The following is a description of a gene set: Any process that modulates the frequency, rate or extent of the chemical reactions and pathways involving polysaccharides. Mouse Gene Set: GOBP_REGULATION_OF_POLYSACCHARIDE_METABOLIC_PROCESS species: Mus musculus, and this is the list of marker genes: Phlda2, Pdgfb, Epm2aip1, Cltc, Smpd3, Prkag3, Akt2, Ppp1r3g, Ppp1cb, Phka1, Enpp1, Ptger4, Mtor, Gck, Tgfb1, Gcgr, Hmgb1, C1qtnf2, Akt1, Ppp1r3b, Grb10, Inpp5k (NCBI Gene Id 192772), Has2, Pomc, Phkb, Phkg2, Khk, Phkg1, Ppp1r3e, Pth, Ins2, Ppp1r3a, Igf2, Egf, Insr, Esrrb, Adcy10, 1810024B03Rik, Ap2a1, Ppp1r3f, Igf1, Pask, Ppp1ca, Ppp1r3d, Gsk3b, Adra1b, Rubcnl, Ppp1r3c, Nfkb1 (NCBI Gene Id 18033), Gfpt1 (glutamine fructose-6-phosphate transaminase 1), Irs1, Ins1, Sorbs1 (NCBI Gene Id 75688), Dyrk2, Irs2